Given this list of marker genes NACA, TLL2, ACTN3, DLL1, MSTN, MTM1, IGF2, here is a description of the gene set: Human Gene Set: GOBP_REGULATION_OF_SKELETAL_MUSCLE_TISSUE_GROWTH Any process that modulates the frequency, rate or extent of skeletal muscle growth. species: Homo sapiens